Given this list of marker genes ACSS1 (acyl-CoA synthetase short chain family member 1), ALDH2, ALDH1A1, ADH6, ADH7, ADH1C, ADH5, ADH1B (alcohol dehydrogenase 1B (class I), beta polypeptide), ADH4, ALDH1B1, ADH1A, ACSS2, here is a description of the gene set: Ethanol oxidation studied in species Homo sapiens Human Gene Set: REACTOME_ETHANOL_OXIDATION